Given this list of marker genes OXT, DGAT2, CDC14B, VAV3, XPO6, COX18, MRPL58, PLSCR1, TTC39B, NLRC3, TMTC4, ACOXL, SCG5, TIMP2, GOLM1, TRIP12 (thyroid hormone receptor interactor 12), TFF2, CPLANE1, IL18RAP, SFT2D2, HLA-E, DPYSL2, NAB2, IGSF11, FBXL17, NCMAP, RGS1, FAM8A1 (family with sequence similarity 8 member A1), SLC32A1, HSD3B2, SEPTIN6, PREB, ANTKMT, IDO2, PPT2, ANGPTL2, NHSL2, TM4SF5, SLC9A6, ZNF18, ELL, HSD17B4, ACACB, ABI2, CDCA4, MISP (mitotic spindle positioning), ALG5 (NCBI Gene Id 29880), PON1, RPS6KA3, PRRT1, CLINT1, CTNND1, SEPTIN8, CERS5, CYFIP1, ARHGEF1, SLURP1, SETD3, ITGAL, INF2, DYNLL2, PLCXD2, PPP1R12C, CNMD, KCND1, TMEM176B, AGFG1, ABCG4, ANKRD39, TMEM181, KCNAB2, ARHGAP39, SRPK1, TRNAU1AP, PDHA1, TMPRSS5, PRMT2 (protein arginine methyltransferase 2), CRTC3, HUWE1, KLF3, ACTL10, AQP9, TNRC6B, REEP3, PRKAR1A (NCBI Gene Id 5573, protein kinase cAMP-dependent type I regulatory subunit alpha), FAM222A, DDX50, MAP1LC3B, KLRK1, CATSPERD, ST6GALNAC5, TMT1A, FAM118A, IFIT1, OVOL1, FLNA, NCOR1, FBXO6, NRAP, RECK, MTMR12, CCDC102A, PLAU, HACD3, DMTN, ITGA4, SLC5A3, ATP5MF, VGLL4, TBX21, BIRC2, CLDN15, UBXN8, TMX4, HMG20A, CCDC85B, KCNMB4, ZNRF1, RNF19A, ITGB1, C8orf74, B3GALT6, LGALSL, UBE2B, AIRN, TOMM7, ZNF287, LUM, RNPEPL1, PATL2, SRGAP2, PRAM1, TSHZ1, TSPAN13, ARHGEF4, HECTD1, FRYL, BCL2A1, SUCO, WAPL, NABP1, KIFC1, UBE3B, SIDT1, RPL13A, MYL6, SPO11, FOCAD, RAP2B, TMIGD1, TMEM9B, ATP8A2, AKNA, ARHGAP5, TMEM234, CAMK2N1, PXYLP1, TNFAIP8L1, CLCA2, PFDN5, CEL, HMOX1, MSMO1 (methylsterol monooxygenase 1), PIK3R5, NPHS2, C19orf47, PTMS, SLC22A8, SSBP4, C1orf21, ORM1, LDB1, PGAP6, PDK1, DOK2, SLAMF6, C19orf12, GPR15, EXOSC8, MLLT6, GADL1, PSMA2, CDC25B, IKZF4, PPP1R18, KCNK7, MBOAT1, PUS3, ANXA6, LRP10, BRD10, HIGD2A, STIM1, MGST2, GLUD1, ABCC5, CCDC88B, PAGR1, here is a description of the gene set: from publication Konuma T, Nakamura S, Miyagi S, Negishi M, Chiba T, Oguro H, Yuan J, Mochizuki-Kashio M, Ichikawa H, Miyoshi H, Vidal M, Iwama A (PMID 21540074) Genes down-regulated in comparison of B cells versus CD4 T cells. Human Gene Set: GSE27786_BCELL_VS_CD4_TCELL_DN species: Homo sapiens Each fraction of mouse hematopoietic cells was purified by cell sorting from bone marrow of 8-week-old C57BL/6 mice, and its gene expression was analyzed.